Given this list of marker genes mt-Tr, Gm8357 (predicted gene 8357), mt-Tg, Ttc3, mt-Nd3, mt-Ti, mt-Tp, Mir6236, mt-Tm, mt-Nd2, mt-Co2, mt-Tc, mt-Ty, Duxf1, mt-Td, Gm15564, Sfi1, mt-Nd4l, mt-Nd4, Ugt1a1, here is a description of the gene set: Genes containing one or more binding sites for (Mbtps2 or Yy2) in their promoter regions (TSS -1000,+100 bp) as identified by GTRD version 20.06 ChIP-seq harmonization. species: Mus musculus Mouse Gene Set: MBTPS2_YY2_TARGET_GENES from publication Yevshin I, Sharipov R, Kolmykov S, Kondrakhin Y, Kolpakov F (PMID 30445619)